Given this list of marker genes APLP2, OSBPL6, SLC22A5, IFT80, FGB, SLC2A3, NUP50, MBTPS1, AMZ1, KBTBD13, DUSP8, MGME1, SLC25A33, FARSA, NHSL2, ABLIM1, PRELP, LSP1, TMEM239, IGFLR1, ST6GALNAC4, NEUROD2, LUC7L3, SKAP1, ZNF25, FSCN3, EEF1B2, CAMK1D, MADCAM1, SPIRE1, RFC1, GPR179, LRMDA, RABEPK (NCBI Gene Id 10244), ARHGAP45, TRHR, NPAS3, CCDC126, TSPAN32, HOOK1, KCNJ3, KAT2B, PRXL2C, LTC4S, KIAA0319, DDX4, DBP, KIAA0040, SLC7A7, ZFR2, EBF1, AKAP7, CLEC4E, TRAIP, GIMAP4, KLHDC8A, ANKH (ANKH inorganic pyrophosphate transport regulator), SH3BP2, MSX1, ITGA4, IL16, KIDINS220, WDR6, GRM1, OR51B6, DNTT, GLI1, ATXN7L3B, KDF1, CD247, SNRNP70, MPZL2, NRP1, SLC4A7, ZC3H4, ANGPTL8, CDC14B, ITPR3, WNK4, GSE1, PIM2, C19orf12, CABLES2, PAXX, GPR63, PVALB, CASKIN1, INCA1, CLDN3, RYR2, AK8, SLC12A6, DOLPP1, FAM221A, APEX1, KLC3, LAMA1, WHRN, EBF4, TCF7L1, METTL26, PPP1R3A, CCT6B, ENTPD5, BEND5, COX10 (NCBI Gene Id 1352), LIMK2, EPSTI1, MPP4, PTPRA, KLF3, NCKAP5 (NCBI Gene Id 401013), CDCP1, PDK2, UPF3A, GNG3, ZNF329, MAP4K2, PGPEP1L (pyroglutamyl-peptidase I like), ZFP36, SELP, UTS2R, ALDH2, HEXB, GRAMD4, PRKD3, POP5 (NCBI Gene Id 51367), IFI27L2, BCL7C, PRSS37 (NCBI Gene Id 378189), GPX6, WDR38, TMEM35A, LLGL2, RCN1, MPI, FCMR, RAMP2, CYP2S1, TMEM86B, RRAS2, CRHR2, GEMIN6, RPL3, PATL2, TTC13, MUC5B, PIM1, CDC25B, SYNGR1, ADSS2, MRC2, GABRG1, SBF2, PELI1, SYT8, GAS2L1, CD2AP, NUDT14, TMEM245, HOXC10, USP28, ARGLU1, SPTBN1, PIK3R5, HMG20A, TMC4, SUN2, PTPN4, PRG4, TCF7, B3GNT6 (NCBI Gene Id 192134), WDR26 (NCBI Gene Id 80232), ANGEL1, ABCG1, CCDC186, BCORL1, EXOG, TRMT12, USP31, PAFAH2, SFXN3, FBXO15, CCN3, CFAP91, FBXO31, ITGA6, HNRNPAB, REPIN1, IL17RA, AKAP8, FXYD1, CCS, OTOF, TMEM231, PTPRCAP, TUBE1, STC1, BCL2, CCDC83, here is a description of the gene set: Genes up-regulated in bone marrow-derived macrophages with MLL4 knockout: 2h LPS versus 4h LPS. studied in species Homo sapiens Histone methyltransferases catalyze site-specific deposition of methyl groups, enabling recruitment of transcriptional regulators. In mammals, trimethylation of lysine 4 in histone H3, a modification localized at the transcription start sites of active genes, is catalyzed by six enzymes (SET1a and SET1b, MLL1–MLL4) whose specific functions are largely unknown. By using a genomic approach, we found that in macrophages, MLL4 (also known as Wbp7) was required for the expression of Pigp, an essential component of the GPI-GlcNAc transferase, the enzyme catalyzing the first step of glycosylphosphatidylinositol (GPI) anchor synthesis. Impaired Pigp expression in Wbp7-/- macrophages abolished GPI anchor-dependent loading of proteins on the cell membrane. Consistently, loss of GPI-anchored CD14, the coreceptor for lipopolysaccharide (LPS) and other bacterial molecules, markedly attenuated LPS-triggered intracellular signals and gene expression changes. These data link a histone-modifying enzyme to a biosynthetic pathway and indicate a specialized biological role for Wbp7 in macrophage function and antimicrobial response. Human Gene Set: GSE30971_2H_VS_4H_LPS_STIM_MACROPHAGE_WBP7_KO_UP from publication Austenaa L, Barozzi I, Chronowska A, Termanini A, Ostuni R, Prosperini E, Stewart AF, Testa G, Natoli G (PMID 22483804)